The following is a description of a gene set: Human Gene Set: GOBP_REGULATION_OF_GLUCAGON_SECRETION Any process that modulates the frequency, rate or extent of the regulated release of glucagon. studied in species Homo sapiens, and this is the list of marker genes: FFAR4, CARTPT, PASK, SYT7, CRH, IL6, AIMP1, LEP